The following is a description of a gene set: species: Mus musculus Mouse Gene Set: GOCC_THO_COMPLEX The THO complex is a nuclear complex that is required for transcription elongation through genes containing tandemly repeated DNA sequences. The THO complex is also part of the TREX (TRanscription EXport) complex that is involved in coupling transcription to export of mRNAs to the cytoplasm. In S. cerevisiae, it is composed of four subunits: Hpr1p, Tho2p, Thp1p, and Mft1p, while the human complex is composed of 7 subunits., and this is the list of marker genes: Thoc5, Thoc2l, Thoc1, Thoc6, Thoc2, Thoc7, Thoc3